Given this list of marker genes CEACAM1, WNT4, PCSK9, CCDC40, MAN2A1, SOD2, HMGCS2, RB1CC1 (NCBI Gene Id 9821), ARF6 (NCBI Gene Id 63379), PHF2, PCK1, IL10, WNT3A, SEC63, SMARCB1 (SWI/SNF related, matrix associated, actin dependent regulator of chromatin, subfamily b, member 1), RPS6KA1 (NCBI Gene Id 6195), EZH2, ONECUT2, UGT1A10, PRMT5, NKX2-8, NPC1, PDX1, E2F8, NAGLU, PKD2, UGT1A9, UGT1A7, UGT1A8, PROX1, TGFBR3, AURKA, RPS15, TGFA, UPB1 (NCBI Gene Id 51733, beta-ureidopropionase 1), LSR, IL6, RHBDD3, SP3, IHH, WNT1, NOTCH1, RPGRIP1L, ERRFI1, TBX3, TGFB1, DUT, ONECUT1, PIK3CA, PTN, RELA, LIPA, BAAT, UCP2, MKS1, RCBTB2, MESP1, JUN, PCNA, ELK1, SRD5A1, CEBPA, NIPBL, HSPA12A, CAD, FLT3, CCND1, PNPT1, HNF1A, ACADM (NCBI Gene Id 51779), ARID5B, COBL, HLX, SRSF5, NODAL, CLDN1, ZMPSTE24, SMAD3, PTCD2 (pentatricopeptide repeat domain 2), UPF2, HNRNPD, CEBPG, FOXH1, CITED2, HES1, IGF2R, NF1, TNFAIP3, RARA, HNF1B, JARID2, CPS1, KRAS, GLI1, CUL3, VTN, DBP, FRZB, GFER, FGL1, CSNK2A2, SOX17, NOTCH2, LIMS2, NPHP3, CEBPB, MDK, ITGA2, OTC, MET, CPT1A, ALDH1A2, CFLAR, RTN4, ADA, PCK2, ASS1, PRKCSH, MED1, PPDPF, TAF10, ATF2, FBXW7, HGF, GUCD1, GATA6, SOX9 (NCBI Gene Id 6662), CYP1A1, SLC7A5, DNAAF1, CD2AP, SULF2, ZIC3, RAP1A, TNF, PTCH1, CDK5RAP3, E2F7, ACAT1, HPN, XBP1, SRSF1, CCDC39, MPST (mercaptopyruvate sulfurtransferase), PKD1, here is a description of the gene set: Human Gene Set: GOBP_HEPATICOBILIARY_SYSTEM_DEVELOPMENT species: Homo sapiens The progression of the hepaticobiliary system over time, from its formation to the mature structure. The hepaticobiliary system is responsible for metabolic and catabolic processing of small molecules absorbed from the blood or gut, hormones and serum proteins, detoxification, storage of glycogen, triglycerides, metals and lipid soluble vitamins and excretion of bile. Included are the synthesis of albumin, blood coagulation factors, complement, and specific binding proteins.